Given this list of marker genes ALB (NCBI Gene Id 29004), HLA-DRB1, RFX5, PLG, P4HA2, PTPN22, TF, RFXAP, SERPINE1, B2M, HLA-B, FTH1, CIITA, RFXANK, here is a description of the gene set: An abnormal concentration of globulins in the blood. Albumin makes up more than half of the total protein present in serum. The remaining blood proteins except albumin and fibrinogen (which is not in serum) are referred to as globulins. The globulin fraction includes hundreds of serum proteins including carrier proteins, enzymes, complement, and immunoglobulins. Most of these are synthesized in the liver, although the immunoglobulins are synthesized by plasma cells. Globulins are divided into four groups by electrophoresis. The four fractions are alpha1, alpha2, beta and gamma, depending on their migratory pattern between the anode and the cathode. Abnormal circulating globulin concentration Human Gene Set: HP_ABNORMAL_CIRCULATING_GLOBULIN_CONCENTRATION species: Homo sapiens